The following is a description of a gene set: from publication Naba A, Clauser KR, Hoersch S, Liu H, Carr SA, Hynes RO (PMID 22159717) Genes encoding proteoglycans Human Gene Set: NABA_PROTEOGLYCANS One hallmark of ECM proteins is their domain-based structure. Exploiting this characteristic, we established a list of diagnostic InterPro domains commonly found in ECM proteins. We know that some of the domains used to select positively for ECM proteins are also found in transmembrane receptors and proteins involved in cell adhesion (growth factor receptors, integrins, etc) that do not belong to the ECM. These families of proteins also display a subset of specific domains and transmembrane domains incompatible with definition as “extracellular matrix” proteins. Therefore, a second step comprised a negative selection using another set of domains and a transmembrane domain prediction. Manual curation of the matrisome lists also allowed us to add a very few known ECM proteins that do not contain any known domains. Protein-centric predictions were then converted to gene-centric lists. Finally, knowledge-based annotation of these gene lists allowed us to define subcategories within the core matrisome; namely, ECM glycoproteins, collagens, and proteoglycans. We also defined separate lists of domains commonly found in 1) ECM-affiliated proteins (proteins that share either some architectural similarities with ECM proteins or that are known to be associated with ECM proteins; 2) ECM regulators: ECM-remodeling enzymes, crosslinkers, proteases, regulators etc.; 3) secreted factors, many of which are known to bind to ECM and others that may. As for the core matrisome list, we also defined lists of domains that excluded mis-assigned proteins from these categories. Using similar bioinformatic pipelines as for the core matrisome, we defined three categories of “matrisome-associated” proteins: ECM-affiliated proteins, ECM regulators, and secreted factors. studied in species Homo sapiens, and this is the list of marker genes: OGN, PODNL1, HAPLN2, BCAN, KERA, SRGN, ASPN, HAPLN3, CHADL, IMPG2, DCN, IMPG1, OPTC, SPOCK3, HAPLN1, SPOCK1, LUM, PRG2, NYX, BGN, CHAD, EPYC, PRELP, PODN (podocan), FMOD, OMD, VCAN, ESM1 (endothelial cell specific molecule 1), PRG4, SPOCK2, NCAN, ACAN, HSPG2, HAPLN4, PRG3